The following is a description of a gene set: Genes down-regulated in primary adipocytes compared to preadipocytes. studied in species Homo sapiens Uncontrolled expansion of adipose tissue leads to obesity, a public health epidemic affecting >30% of adult Americans. Adipose mass increases in part through the recruitment and differentiation of an existing pool of preadipocytes (PA) into adipocytes (AD). Most studies investigating adipogenesis used primarily murine cell lines; much less is known about the relevant processes that occur in humans. Therefore, characterization of genes associated with adipocyte development is key to understanding the pathogenesis of obesity and developing treatments for this disorder. To address this issue, we performed large-scale analyses of human adipose gene expression using microarray technology. Differential gene expression between PA and AD was analyzed in 6 female patients using human cDNA microarray slides and data analyzed using the Stanford Microarray Database. Statistical analysis for the gene expression was performed using the SAS mixed models. Compared with PA, several genes involved in lipid metabolism were overexpressed in AD, including fatty acid binding protein, adipose differentiation-related protein, lipoprotein lipase, perilipin, and adipose most abundant transcript 1. Novel genes expressed in adipocytes included E2F5 transcriptional factor and SMARC (SWI/SNF-related, matrix associated, actin-dependent regulator of chromatin). PA predominantly expressed genes encoding extracellular matrix components such as fibronectin, matrix metalloprotein, and novel proteins such as lysyl oxidase. Despite the high differential expression of some of these genes, many did not differ significantly likely due to high variability and limited statistical power. A comprehensive list of differential gene expression is presented according to cellular function. In conclusion, these studies offer an overview of the gene expression profiles in PA and AD and identify new genes with potentially important functions in adipose tissue development and obesity that merit further investigation. from publication Urs S, Smith C, Campbell B, Saxton AM, Taylor J, Zhang B, Snoddy J, Jones Voy B, Moustaid-Moussa N (PMID 15051823) Human Gene Set: URS_ADIPOCYTE_DIFFERENTIATION_DN, and this is the list of marker genes: ADORA1, CD37, PPP2R1A, PTGDS, THBS2, COL3A1 (collagen type III alpha 1 chain), LOX, AGTRAP, MED1, DCN, COL4A2, TMEM179B (transmembrane protein 179B), PTPRN, COL6A1, CEBPA, MMP9, ZNF587B, E2F4, SPARC, COL6A3, PSG9, LRP5, LRP3, FN1, NUMA1, PPARD, ZNF169, LUM, ROM1, LOXL1, OSGIN1